The following is a description of a gene set: Human Gene Set: MIR3179 from publication Chen Y, Wang X (PMID 31504780) species: Homo sapiens Genes predicted to be targets of miRBase v22 microRNA hsa-miR-3179 in miRDB v6.0 with MirTarget v4 prediction scores > 80 (high confidence targets)., and this is the list of marker genes: SUMO2, ZBTB20, EIF1, FGF12, PPP3CB, SINHCAF, ZSCAN30, CENPO, ARL3, PPP1R1B, RNF34, TMEM127, ATOH8, NYNRIN, UBE2D2, SP6, SUPT3H, SCRN1, TFAP2B, SMG6, PCDHGA12, CCR5, SSPN, DSEL, PAK2, RNASE3, GANAB, RNASE2, SCNM1, NIFK, FBXO42, RAPGEF2, SZRD1, DAAM2, PTPRD, SEC14L4, TOR1B, MAF, KLHL8, SRCAP, ZDHHC3, NTRK2, KLHL9, IKZF4, KLHDC7B, SRF, ANKRD52, STX1A, GPR173, FBRS, NMD3, AAK1, TRIM22, TSR1, SOX14, TCL1B, MTHFS, TP53INP2, ABHD4, ANGPT4, EEIG1, JOSD1, EHD1, TSPAN5, TLE3, C1QTNF2, TMEM145, CUL2, C19orf47, FCER2, TGM2 (transglutaminase 2), CLEC4D, HIF1AN, KCNC4, CCDC85C, LYZ (lysozyme), ODAD1, MRPL4, TLCD3A, ATP1A3, TAS2R1, ALG8, BTRC, DET1, SRP68, CAMK1D, TRAF3, RPF1, PBX1, ZNF585B, C2CD2L, CELSR2, AFTPH, SYNGAP1, WDTC1, RIMS4 (NCBI Gene Id 200225), LARP1, PCP4L1, WTAP, PNKD, EFNA3 (NCBI Gene Id 1944), RFTN2, PPP4R3A, P2RY4 (NCBI Gene Id 5030), GTPBP3, PIP4K2C, NONO, ATP2A1, TCP11X2, ST20-MTHFS, CTDSP2, TRIM8, RILPL2, PTPMT1, ZNF691, VAMP2, HDAC5, RERG, PADI1, XKR6, PAFAH1B2, GAS7, CLVS2, USP49, SBNO1, MTCL2, MRPS18C, STK10, RARG, SPATA33, TPTE (NCBI Gene Id 7179)